The following is a description of a gene set: Human Gene Set: GOCC_MITOCHONDRIAL_INTERMEMBRANE_SPACE_PROTEIN_TRANSPORTER_COMPLEX Soluble complex of the mitochondrial intermembrane space composed of various combinations of small Tim proteins; acts as a protein transporter to guide proteins to the Tim22 complex for insertion into the mitochondrial inner membrane. studied in species Homo sapiens, and this is the list of marker genes: TIMM8B, TIMM8A, TIMM9, TIMM10B, TIMM10, TIMM13